Given this list of marker genes CD19 (CD19 molecule), TCF4, LXN, BLNK, FCGR2B, ZNF398, MEMO1, IDH3A, PABPN1, CMBL, WASF2, CDCA8, POU2AF1, SLPI, HP, FAM8A1, ANXA4, TWSG1, DOCK5, KLRG1, CCDC28B, PPL, PSMD8, IRF5, FANCM, MRPS15, MBD4, GZMB, SWAP70, EGR2, CLPS, TP53INP2, CD9, POU3F2, FCER2, CD22, RHD, JARID2, C1QTNF12, HS3ST1, IL18RAP, HK2, EBF1, ACTB, CREBRF (CREB3 regulatory factor), CDKN1A, FADS1, VPREB3, IGHG1, PRKCB, ANXA1, MED12L, TTC14, CD244, CD81, BATF3, LGALS3, PLXNB2 (plexin B2), KCNA4, IFITM3, HDC, CA2, PHF13, ENTPD1, ANXA2, AK3, MRPS24, RBX1, LAMC1, HLA-DRB1, WNK2, LAT2, CD86, CXXC5, IGLC7, ARPP19, TBCE, CCL1, RYR1, IL1B, ZPBP, AURKB, EMP1, RALY, MYL4, VMP1, TIMM10, DSPP, CFP, GJA3, ALCAM, PRR5, KRTCAP2, S100A8, ADAM8, HS2ST1, CD74, APOBEC1, CCR2, CD40, FOXA3, NAPSA, LY86, EEA1, RECQL5, IL1RN (interleukin 1 receptor antagonist), CHD7, TNFRSF8, MECR, LITAF, KMT2E, CLCC1, P3H4, MAD2L1BP, HHEX, CTSA, CXCR2, ENSG00000286190, BLK, ZC3H12C, ADCY6, GALNT3, IGF1R (insulin like growth factor 1 receptor), TNXB, RPS6KB1, CD79B, MYB, CMC2, CUZD1, CXCR5, GZMA, ADCK1, BBLN, MAN2A1, AMFR, ZNF821, ENTPD2, ENTPD6, CCR6, SORBS1, LACTB2, AHRR, MFHAS1, MXD4, TBR1, GOLGA7, MYADM, GMFG, MTMR1, KLRD1, ITGAV, RSU1 (Ras suppressor protein 1), FAM89B, RNF14, SS18L2, GNAI2, SLC4A1, LYL1, SYK, MTNR1A, LMO2, AHNAK, KPNA2, IGKC, DENND5A, SVIL, PTGER3, RORA, ANXA7, LAPTM5, CARHSP1, CD38, PIAS3, IMPA1, PPP3CA, IRF8, CASP3, RGS5, SMC4, HSPA2, ID2, ENPP1, IL4I1, PAM16, CD47, GABARAPL1, CHEK2, GPD2, CD4, CD180, MTM1, RPL30, KIF22, CCDC93, CA1, RGL1, ALDH2, KMT2A, HLA-DQA1, RECQL, here is a description of the gene set: studied in species Homo sapiens Human Gene Set: KAECH_DAY15_EFF_VS_MEMORY_CD8_TCELL_UP Genes up-regulated in effector CD8 T cells at contraction phase (day 15 after LCMV-Armstrong infection) compared to memory CD8 T cells (day 40+ after LCMV-Armstrong infection). How and when memory T cells form during an immune response are long-standing questions. To better understand memory CD8 T cell development, a time course of gene expression and functional changes in antigen-specific T cells during viral infection was evaluated. The expression of many genes continued to change after viral clearance in accordance with changes in CD8 T cell functional properties. Even though memory cell precursors were present at the peak of the immune response, these cells did not display hallmark functional traits of memory T cells. However, these cells gradually acquired the memory cell qualities of self-renewal and rapid recall to antigen suggesting the model that antigen-specific CD8 T cells progressively differentiate into memory cells following viral infection. from publication Kaech SM, Hemby S, Kersh E, Ahmed R (PMID 12526810)